The following is a description of a gene set: species: Homo sapiens Various sensory and motor branches of the glossopharyngeal nerve supply nerve connections to the pharynx and back of the tongue. The branchial motor component contains motor fibers that innervate muscles that elevate the pharynx and larynx, and the tympanic branch supplies parasympathetic fibers to the otic ganglion. Human Gene Set: GOBP_GLOSSOPHARYNGEAL_NERVE_DEVELOPMENT, and this is the list of marker genes: HOXB3, HOXA3, HOXD3, NAV2, PLXNA4